Given this list of marker genes SYCE1, ELOVL4, CDH3, RP1L1, SAMD7, MYO5A, TIMP3, PRPH2, CHST6, PEX1, BBS5, MFSD8 (NCBI Gene Id 256471), EFEMP1, PROM1, AHDC1, CCNQ, CFI, IMPG2, BEST1, IMPG1, CFH, here is a description of the gene set: Macular dystrophy is a nonspecific term for premature retinal cell aging and cell death, generally confied to the macula in which no clear extrinsic cause is evident. species: Homo sapiens Human Gene Set: HP_MACULAR_DYSTROPHY Macular dystrophy